The following is a description of a gene set: Human Gene Set: GOBP_PROTEIN_RNA_COMPLEX_DISASSEMBLY The disaggregation of a protein-RNA complex into its constituent components. species: Homo sapiens, and this is the list of marker genes: FAF2, DNAJC17, DYRK3, KLC1, TRIM21, TFIP11, VCP (NCBI Gene Id 94731), KIF5B, ZFAND1